Given this list of marker genes RP2, GJA10, SLC4A10, SLC38A8, BFSP2, CABP1, KIFC3, RDH12, GPR179, LUM, TIMP3, EPAS1, PDE6G, CYP4V2, MYO3B (myosin IIIB), CRYBB1, CRB2, PDE6A (phosphodiesterase 6A), CNGB1, REEP6, CEP250, SIX6, USH1G, EYS, GRK7, CACNA1F, RHO, CLN5, VSX2, GPR143, RDH11, COL18A1, ATF6, CLIC5 (chloride intracellular channel 5), RS1, BBS4, NOB1, OPN1MW, LAMC3, BEST1, CRYGN, RABGGTB, EFEMP1, OPN1MW2 (NCBI Gene Id 728458), BBS10 (NCBI Gene Id 79738), EML2, RP1, LRIT3, ATP8A2, SPATA7, RPGRIP1, OPN1MW3, ARL6 (ADP ribosylation factor like GTPase 6), DHRS3 (NCBI Gene Id 9249), GUCA1ANB-GUCA1A, RDH5, HPS1, CRYGB, ABCC6, CCDC66, OAT, TYR, PAX6, CRYBA1, CRYBA2, PDCL, NDP, LAMB2, CNGB3, RPE65, GLRA1, CNNM4, PCDH15, CPLX4, ROM1, GNAT1, CLDN19, MYO9A, NYX, VAX2, NXNL2, RAX2, SOX14, BBS5, GUCA1C (guanylate cyclase activator 1C), ZNF513, RDH8, HMCN1, BBS1, FAM161A, TULP1, TRPM1, TULP2, GUCA1B, CNGA3 (cyclic nucleotide gated channel subunit alpha 3), PDE6D, RGS9BP, RABGGTA (NCBI Gene Id 5875), PCARE, OPN1LW, GNAT2, PDE6H, LRIT1, SLITRK6, ATXN7, RBP3, WFS1, AOC2 (NCBI Gene Id 95864), CLN6, LRAT, OPN1SW, NR2E3, SLC24A1, WDR36, PPEF2, RRH, GUCA1A, UNC119, BBS2, SFRP5, GJA3, WHRN, RPGR, ABLIM1, PRR4, RAX, IMPG1, CRYGC, OPA1, CABP4, CNGA1, CRB1, ABCA4, CRYBB3, PRPH2, MIP, ELFN1, KCNK9, TH, GABRR2, CDH23, CRYGD, CDH3, MFRP, OPN5, GUCY2D, GNAT3, CLRN1, ADGRV1, CACNB4, RBP4, CACNA2D4, MYO7A, RGS16, KERA (NCBI Gene Id 1256), COL2A1, CRYZ, LCTL, POU4F3, USH1C, CACNB2, KRT12, GRM8, GRK1, RGR, BBS9, PITPNA, CPLX3 (complexin 3), NRL, RORB, SEMA5B, EYA4, VSX1, PDE6C, OPN4, CRX, CRYBB2, ARR3, IRX5, COL1A1, CRYAA, RCVRN, CRYBA4, FSCN2, GJC1, DNAJC19, DRAM2, COL11A1, CHRNB2, OPA3, PDE6B, GLRB, BBS7 (NCBI Gene Id 55212), CRYGS, MYO3A, POU6F2, GUCY2F, USH2A, SIX3, PDC, NR2E1, RGS9, RIMS1, RP1L1, RLBP1, SLC45A2, CRYBG3, EYA3, AIPL1, CRYGA, GRM6, ZIC2, KCNJ10 (NCBI Gene Id 3766), PAX2 (NCBI Gene Id 5076), DLL4, CLN8, TGFBI, RDH10, PRCD, CABP2, MKKS, PPT1, RD3 (NCBI Gene Id 343035), IMPG2, TACSTD2, GJD2, CHM, here is a description of the gene set: studied in species Homo sapiens Human Gene Set: GOBP_SENSORY_PERCEPTION_OF_LIGHT_STIMULUS The series of events required for an organism to receive a sensory light stimulus, convert it to a molecular signal, and recognize and characterize the signal. This is a neurological process.